Given this list of marker genes Lhfpl6, Map3k20, Nat8l, Grm7, Golm2, Zfp318, Chst2, Ms4a5, Gna13, Tafa1, Trpc7, Gabbr1, Mex3a, Phf20, Bcl2, P4ha3, Siah2, Htra4, Pcdhgc3, Nat8f2, Casp8, Ubtf, Ly6g6c, Zfp827, Trpc6, Iqgap2, Acss1, Slc33a1, Nphp3 (nephronophthisis 3 (adolescent)), Pdxk, Zfp39, Idua, Fam107a, Enpp6, Slc28a2, Zfp691, Saa4, St8sia5, Zfp704, Smo, Shisa6, Cfap74, Slc24a2, Shisal1, Cxcl15, Aptx, Rgs5, Uimc1, Srgap3, Rassf2, Asb13, Pld5, Wars2, Rusf1, Terf2ip, Clec2l, Cd33, Prpf4, Fyco1, Cd274, Slc39a14 (NCBI Gene Id 213053), Cgas, Tmt1a3, Kank2, Tgds, Zfp663, Slc1a2, Corin, Celf4, Reps2, Pcdh10, Cox15, Steap2, Sike1, Zyg11b, Tnfrsf13c, Chst3, Lama3, Anks1b, Csrnp2, Prc1, Slc17a5, Ttn, Homer1, Hpca, Irag1, D630039A03Rik, Ap1g1, Ttc12, Tmem26, Pofut1, Triobp, Itgam, Pcdhgb5, Fbxl17, Pcdhga6, Garre1, Nos1, Kcnv1, Nr4a2, Fam174b, Rpusd2, Tcte1, Shroom3, Baz2b, Rnf150, Cyp7a1, Bpifa6, Smyd3, Tacr2, Pcdha4b, Cyp4a31, Gls, Sh3bgrl2, Vamp5, Agtpbp1, Chic1, Tmem151b, Yipf6, Stxbp4, Lpp, Tph1, Telo2, Prss42, Ppfibp2 (PTPRF interacting protein, binding protein 2 (liprin beta 2)), Cer1, Fgf11, Cfap97, Lrtm2, D430019H16Rik, Gm4841, Acsl4, Trub2, Arih1, Tfap2b, Prss23, Mapk10, Map3k7, Tacr1, Mbd5, Chd7, Magee2, Fbrs, Dhh, Eogt, Plcb1, Senp1, Stat6, Scn3b, Klhl13, 1700025G04Rik, Cdk6, Dio2, Alox8, Marchf1, Plp1 (NCBI Gene Id 18823, proteolipid protein (myelin) 1), B3gnt9, Sdf4, Erg, Ebf3, Prelid3a, Rspo1, Rab2b, Atp11a (ATPase, class VI, type 11A), St18, Edaradd, Bdh1, Tns4, Cnot7, Setd7, Mtmr12, Pcdhga8, Dppa1, Asap3, Bmp7, Trim67, Ngfr, Orai2, Adarb2, Cd27, Znrf3, Psd2, Pate9, Zbtb7c, Grk3, Camk1d, Tmem196, Myorg, Diras2, Vps37a, Pcdhga9, Vangl2, Rorb, Cplx2, Fcrl6, Ccdc3, Bcl2l11, Ar, Wrn, Zeb2, Zfp799, Trim16, Snai2 (NCBI Gene Id 20583), Cd84, Adamts17, Unc93a, Mta3, Camk2a, Acot2, Gpr68, Ppp1r16b, Mnt, Ceacam18, Papss2, 3425401B19Rik, Gtf2h2, Greb1, Pogk, Napepld, Zfp91, Trpc5, Katnip, Kat6a, Kcnj15, Snurf, Serinc3, Zfhx3, Cd99l2, Ctdsp2, Lcorl, Klf6, Dido1 (NCBI Gene Id 329580), Hrh1, Lgals12 (NCBI Gene Id 56072), Slc25a11, Xpr1, Oxtr, Galnt13, Pitpnb, Zfp931, Zrsr2, Plpbp, Thsd7a, Iffo2, Ctse, Ehd3, Gdpgp1, Adamts5, Grik3, Rasa2, Atp2b3, Hspb7 (NCBI Gene Id 29818), Snap23, Ajap1, Nlgn3, Eif4e, Unc5a, Prkcg, Pcdhga12, Flrt1, Oacyl, C5ar2, Stxbp5l, Runx3, Hs3st3b1, Mfap3l, Pdzrn3 (NCBI Gene Id 68638), Prrc2b (NCBI Gene Id 98867), Barhl2, Ceacam1, Deptor, Dhdh, Cd2ap, Pclo, Tub, Maf, Amotl1 (NCBI Gene Id 75723), Cdh20, Creg2, Lhx6, Srsf12, Cradd, Lyrm9, Tpgs2, Flnb, Pappa, Napb, Tet2, Ascl1, Pcm1, Prex2, Itga9 (integrin alpha 9), Ssr1, Ifi44, Rsph4a, Cacna2d2, Slc28a2b, Sh3rf3, Gabrb3, Dcaf12, Chrnb4, Gabra2, Slc22a15, Pgm5, Pax3, Slc25a31, Cby2, Ascl4, Atrn, Xrcc3, Aldh5a1, Slc25a12, Wiz, Epha7, Pou3f4, Bend3, Car10, Prlr, Slc4a4, Kif1a, Cd4, Adnp, Zfp37, Ubfd1, Rab9b (NCBI Gene Id 319642), Spx, Ctsc, Rit2, Gabrb2, Tmco1, L1cam, Rufy2, Tgfb2, Angpt2, Nab1, Insyn2a, Kcna2, Myo5a, Dapp1, Podn (podocan), Pilra, Pcdhgc4, Foxk1, Sox1, Calcoco1, Nid1, Tyw3, Rab7, Cnih3, Foxa1, Zfp449, Pcdh17, Vangl1, Dnase1l3, Commd7, Kmt5b, Ano3, Synj2bp, Lnx2, Igsf6, Ift57, Ctbs, Prr5l, Slc6a17, Sema6a, Sin3a, Glra2, Naip6, Sema5b, Gcnt4, Draxin, Dlgap4, Mdm2, Kcnq2, Bmp4, Adamts14, Sfrp1, Frmd5, Col17a1, Adgrf5, Jarid2, Tc2n, Rora, Mthfsd, Nkain2, Tead1, Zfp811, Slc8a3, Neurod2, D630045J12Rik, Liph, Runx1 (runt related transcription factor 1), Dph6, Scd3, Fsd1l (NCBI Gene Id 633268), Adora3, Ildr2, Depdc5, Ncam1, Pafah1b1, Fmn2 (NCBI Gene Id 98584), Arhgap25, Gask1a, Ppp1r1c, Zfp446, Tmod2, Setd3, Foxn1, Prxl2a, Gas2l1, Nab2, Rab6b, Lcp2, Pcdhga11, Zfp74, Ece1, Igsf11, Nlrc5, Fam169b, Asah2, Ints10, Klhl23, Egfl6, Snx12, Pacsin2, Dcdc2a, Mapkbp1, Macroh2a2, Krt222, Katnal1 (NCBI Gene Id 231912), Pcdhga1 (protocadherin gamma subfamily A, 1), Mbnl3, Gnal (NCBI Gene Id 72463), Muc13, Plac9, Slc25a21, Pcdhga7, Zfp248, Cyb5r3, Rslcan18 (NCBI Gene Id 432770), Hivep3, Abcc9, Zfp92, Supt7l, Pdcd4, Vsnl1, Kcnk10, Oxsm, Elovl6 (ELOVL fatty acid elongase 6), Ptchd1, Sh3gl3, Dnlz, Myh11, Kirrel3, S2bpcox16, Usp25, Rab11fip1, Slc31a2, Zfp365, Glis3, Btbd8, Tbx15, Igf1r, Cox10, Prdm12, Samd7, Fbxw5 (F-box and WD-40 domain protein 5), Dusp7, Prokr2, Scn8a, Gfra2, Proser3, Nmrk1, Tti1, Xk, Tmem104, Rad18, Slc2a12, Znrf2, Tamalin, Sh2d2a, Smim19, Erbb2 (NCBI Gene Id 13866), Apba1, Rhou, Cask, Cd300ld, Sim1, Acsm5, Pcdhgc5, Zfp641, Mdfic, Dgkg, Ackr4, Cdh7, Pstpip2, Mafb, Pcdhgb7, Fermt1 (NCBI Gene Id 241639), Uncx, Fbxo31, Zscan29, Adra1b (adrenergic receptor, alpha 1b), D630023F18Rik, Sowahb, Mon1b, Mbtps2, Chst11, Slc7a1 (NCBI Gene Id 264068), Ddo, Prdm8, Cdk13, Zc3h12d, Dock5, Pfkfb2, Ddi2, Dkk1, Man1c1, Rfx3, Jmjd8, Tns1, Fndc3a, Unc5d, Hoxc9, Sys1, Wdr46, Wscd1, Rhobtb1, Il18r1, Trim65, Cmah, Stk32a, Ddx11, Kif17, Thbs2, Rgs17, Maml3, Ptpre, Nrp2, Htt, Ptprb, Pappa2, Snrpn, Gadl1, Arrb1 (arrestin, beta 1), Pirt, Klhdc8b, Nrxn1, Chmp1b2, Ric8b, Itga11, D630003M21Rik, Slc22a8, Slc38a6, Nmnat2, Cntn3, Peg3, Arpp21, Slc10a2, Ceacam2, Onecut2, Stn1, Clvs1, Pard3b, Eef2k, Adcy5, Rgs9bp, Nedd4l, Ubap2l, 1810030O07Rik, Ceacam14, Tlx1, Cat, Mcidas (multiciliate differentiation and DNA synthesis associated cell cycle protein), Rfx7, Ifnlr1, Insr (NCBI Gene Id 319666), Ap1ar, Sh3bp5, Ncan, Brwd3, Zfp46, Dctd, Slc6a6, Camta1, Trp53i11, Pcdhgb2, Mfsd6, Dhfr, Pcdhga2, Nsun3, Rab9, Kat2b, Vps33b, Phf14, Lnpep, E2f8, Impg1, Acp3, Opcml, Kdm6b, Thada, Pik3r5, Sp9, Thsd4, Nfya, Nqo2, Cap2, Gas2l3, Snap25, Dnaaf5, Vwa5b2, Nkap, Kcnc1, Lmo3, Slc8a1, Rims2, Kcnj16, Adam12, Lin7a, Aak1, Mrgpre, Adgra1, Nfat5, Pcdhga4, St8sia3, Cstf3, Cox16, Aggf1, Sox5 (SRY (sex determining region Y)-box 5), Cds2, Fgf12, Igf2, Gm14137, Bmp3, Pign, Actr1b, Rara, Ank2, Pura, Sox7, Rfk, Kcnmb1, Lrrn4cl, Arhgap26, Plxna2, Cend1, Neu1, Ipcef1, Rgr, Lnpk (NCBI Gene Id 99060), Iars1, Zfp488, Pde10a, Acsm2, Cacna1c, Hoxc8, Rgs4, Vegfb, Vipr2, Arhgdib, Rab3c (RAB3C, member RAS oncogene family), Oog4, Nwd1, Pcdhga10, Cd160 (NCBI Gene Id 99838), Rad52, Ulk1, Trpm3, Tmem150c, Lrrc61, Pank1, Pou3f2, Pcdhgb4, Tmem47, Syt15, Nrip3, Zfand2a, Foxn2, Mocs1, Onecut3, Zfp516, Acvr2b, Septin3, Efcab14, Ppp1r9a, Treml2, Tnfrsf11a, Gm14151, Gnaz, Meis2, Man2a2 (NCBI Gene Id 73354), Lamc1, Tmem236, Lbp (NCBI Gene Id 16803), Enpp1, Elp4, Iglon5, Zfp606, Bin2, Tspan18, Akap13, Suz12, Elovl5, Stk10, Tbc1d30, Mecp2, Micall1 (NCBI Gene Id 27595), Kcnip3, Syn3, Bgn, Urod, Pakap, Elfn1, Osr1, Slco2a1, Elfn2, Has2, Skil, Tmem52b, Runx1t1, Grid1, Zfp764, Fhl1, Mapk11, Ilrun, Csf2ra, Lrrc32, Mymk, B4galnt2, Dmrta1, Pcdhga5, Ccdc71l, Cdh12, Bnc2, Epas1, Map7d1, Gcm2, Pigh, Gria3, Cstad, Tafa3, Zfp329, Ttll1 (NCBI Gene Id 319953), Il22ra1, Klf12, Kcnj1, Fblim1, Irf2bp2, Pcdhga3, Elavl3, Nkx2-9, Nup155, Rasal2 (NCBI Gene Id 320357), Heatr6, Rnasel, Ttc4, Slc30a10, Arhgef17, Oprm1, Ski, Deup1, Sytl5, Fbxw28, Zdhhc21, Slc7a8 (NCBI Gene Id 50934), Mlec, 4921509C19Rik, Vapb, Msrb3, Havcr2, Smarca2, Atp2b2, Tubgcp4, Pcdhgb8, Pcdhgb1, Marchf4, Zfp810, Accs (NCBI Gene Id 72467), Gatc, Metrnl, Kmt5a (NCBI Gene Id 98818), Gm38666, Chrnd, Sema5a, Dcaf1, Tcp11l1, Npr3, Creg1, Ms4a4c, Rbbp7, Pcdhgb6, Esr2, Urb2, Adgre5, Sp100, Atxn1, Tmtc3, Dmd, Fam149b, Gjc3, Zfp747, Cnksr2, St8sia1, Hexim2, Trim36, Phactr3, Dynlt5, Nrbp2, Nfasc, Fgf23, Dcx, Zmiz1, Unc13b, Mobp, here is a description of the gene set: Genes predicted to be targets of miRBase v22 microRNA mmu_miR_6903_3p in miRDB v6.0 with MirTarget v4 prediction scores > 80 (high confidence targets). Mouse Gene Set: MIR_6903_3P from publication Chen Y, Wang X (PMID 31504780) species: Mus musculus